Given this list of marker genes FTH1, TLE3, ADM, MTRES1, EFNB1, MYL11, MYL4, HCCS, TNNI1, POPDC3, GLRX, PML, HSD17B11, DIAPH1, TSPAN31, ITIH2, CMBL, AOC3, RAD52, SIX1, SEMA3E, H6PD, SMAD6, FAH, TMUB2, TNNT3, C11orf54 (NCBI Gene Id 28970), MRFAP1, CIRBP, ADARB1, B3GALNT1, COL4A2, EPHX1, IL6ST, HTRA3, GJA1, IGFBP4, IL1R1, TNXB, CST3, CAPN6, ZFHX3, TNNT2, HGF, NMB, MMP14, TSPAN6, COL4A1, RSAD2, PIP5K1B, TRAPPC12, ZNF394, SESN1, ZFR2, GGT5, ACTC1, VSNL1 (NCBI Gene Id 7447), LONP2, CD40, CASP2, FMO1, CARHSP1, MGST3, GAS2, CAND1, GATD3, NRP1, SGCE, TRAF3IP2, CD63 (CD63 molecule), ADAM23, FABP4, SPARCL1, TAPBP, DKK3, SNTB1, PAX3, DAB2, HLX, CCDC6, MAOA, EBF3, HSBP1, DENND5A, SFRP2, LIMCH1, TNNC1, COL3A1, KNG1, RAMP2, COL6A1, PPL, CRIP2, RAB3B, TGFBI, LPAR1, GHITM, TSC22D1, RBM10, RASA4B, LIFR, ZNF32, TRDC, MESD, GPR37L1, EPHB6, SH3BGR, SNAI2, ENPP1, CTDSP2, THBD, PLPP3, ART3, ANG, ZNF878, RAB9A, PHKA2, ZNF419, ITPR1, SMS, CCDC88A, GSTT1, TMEM45A, LITAF, NFYB, THA1P, THRA, FAM50B, SIRT3, ZNF821, COL6A3, MYL1, CDKN2C, TMEM185A, FRMD6, here is a description of the gene set: The insulin/IGF-1 (insulin-like growth factor 1) signalling pathway promotes adipocyte differentiation via complex signalling networks. Here, using microarray analysis of brown preadipocytes that are derived from wild-type and insulin receptor substrate (Irs) knockout animals that exhibit progressively impaired differentiation, we define genes/expressed-sequence tags whose expression in preadipocytes correlates with the ultimate ability of the cells to differentiate. Many of these genes, including preadipocyte factor-1 (Pref-1) and multiple members of the Wnt signalling pathway, are related to early adipogenic events. Necdin is also markedly increased in Irs knockout cells that cannot differentiate, and knockdown of necdin restores brown adipogenesis with downregulation of Pref-1 and Wnt10a expression. Insulin receptor substrate proteins regulate a necdin-E2F4 interaction that represses peroxisome-proliferator-activated receptor gamma (PPARgamma) transcription via a cyclic AMP response element binding protein (CREB)-dependent pathway. Together these define a key signalling network that is involved in brown preadipocyte determination. Human Gene Set: TSENG_IRS1_TARGETS_DN species: Mus musculus from publication Tseng YH, Butte AJ, Kokkotou E, Yechoor VK, Taniguchi CM, Kriauciunas KM, Cypess AM, Niinobe M, Yoshikawa K, Patti ME, Kahn CR (PMID 15895078) Down-regulated in brown preadipocytes with IRS1 knockout vs wild type controls; the knockouts have severe defects in adipocyte differentiation.